The following is a description of a gene set: Genes having at least one occurrence of the motif NNNNNNGGNACRNNNTGTTCTNNNNNN in the regions spanning 4 kb centered on their transcription starting sites. This matches the PGR transcription factor binding site V$PR_01 (v7.4 TRANSFAC). species: Homo sapiens Human Gene Set: PR_01, and this is the list of marker genes: WT1-AS, RAB1B, GSDMA, TECTA, VAMP2, SYNCRIP, AGAP2, IKZF2, ADNP, TRIM63, EMILIN1, MSTN, DLG3, MPRIP, RCN1, SEMA4C, PPP1CC, WNT8B, WNT4, TEX35, ZNF775, PCDH8, PIEZO2, ARMH4, KCTD6, ZNF654, RGS3, OTX2, CD52, KCNJ1, ZMYND8, SKIL, PABPC5, RNF38, JPH1, ETS1, NCDN, CD109, TIMD4, HOXA2, USP54, SLC26A7, LRRTM3, BDNF, MYH4, ADCY6, GRB2, TSPAN33, JMJD1C, MTMR10, DSTN, PMCHL2, ARHGAP6, NDST2, HOXA5, PDZD9, HEPACAM2, EPG5, SLC12A8, CHCHD7, ADGRB3, NCKAP5, TRIB2, MBP, BCL6, RANBP9, TMEM86A, IP6K2, PDGFB, TSC22D3, RTKN, ARHGAP32, RBM24, KLHL5, RAB37, FSTL5, SLC7A8, GDNF, CASZ1, FBXO9, IL27, CCDC126, FES, SREK1, TNIP3, STK35, WFIKKN2 (WAP, follistatin/kazal, immunoglobulin, kunitz and netrin domain containing 2), KCTD4, ELMO1, DNAJA2, RWDD1, TYRO3, PYGM, NHLH1, HIVEP1, ZP3, RAB30, ARSG, KCNH5, ENTREP1, CNGB3, TIMM8A, FGF17, FRA10AC1, HOXC5, ITGA6, BHLHE40, RTL3, OTP, NCOA3, ADAMTSL1, TIE1, SLC17A2, SENP3, BRINP3, PMCHL1, DLG2, CYLD, C2CD2L, AMOT, LARP1B, RBM3, PROX1, HOXC4, CEP57, GIPC2, EPHA7, PLAG1, FAM76B, SCNN1A, LARP4, KHDRBS1, ATF7IP, ELAVL4 (NCBI Gene Id 1996), GREB1, MIA, CD36, NSD1, FIGN, HOXC6, TNS2, FADS6, NIPBL, PCDH9, SDC1, SRGN, TUBB4A, RELCH, AMY2A